The following is a description of a gene set: species: Homo sapiens from publication Chen Y, Wang X (PMID 31504780) Human Gene Set: MIR556_3P Genes predicted to be targets of miRBase v22 microRNA hsa-miR-556-3p in miRDB v6.0 with MirTarget v4 prediction scores > 80 (high confidence targets)., and this is the list of marker genes: MGME1, KCNMB3, KCNN4, ZNF704, TAF1, SAFB, PRTFDC1, G3BP2, SOCS1, ZNF695, PPM1B, CWC25, RIBC1, SMC5, COL4A1, HECW1, RAB22A, FCGR3A, DAPL1, CDH20, CLDND1, RFC3, CPEB3, CNOT2, DAB2IP, S1PR5, FYB1, KIN, HHIPL2, AGFG1, VTI1B, KCNH1, SLC49A4 (solute carrier family 49 member 4), CCN4, PSG2, PTPRF, VDR (vitamin D receptor), IHH, APLF, MED18, PRSS21 (NCBI Gene Id 9065), ERG, UPF1, CIP2A, TEK, KRT12, SENP6, KCTD4, ANGEL2, EHMT2, FCGR3B, PCP4, AP1AR, FGFR2, TOMM20L, MAB21L1, IMPA2, ELAVL4, ZNF33A, PPP2R5C, SENP2, PSG5, ZZZ3, DTX3L, PSG9, LAMA3, TTC1, DCTN4, CNNM4, SLC6A13, MTMR9, ATP6V1C2, ZNF548, TRAPPC8 (trafficking protein particle complex subunit 8), AK4, HOXD1, PI4K2B, MAFB, ELAVL1, GPR180, SLMAP, TYK2, PSG11, GRHL3, PSG3, RCBTB2 (RCC1 and BTB domain containing protein 2), PEX14, CCDC85A, MAPK9, BIRC3, GLIPR1, TCFL5, IKBIP, TRNT1, STX16, CYP3A7, FGF14, CNTN1, YBX1, NR3C2, PKIA, SLC27A3, SOX7 (SRY-box transcription factor 7), TM9SF3, FGFBP1, CHN2, SLC26A9, RGS9BP, CEACAM5, ZIC3, KATNAL1, TRIM36, DNAL1, UNC5C, BRD7, ENPP1, PTPRA, KIAA1958, HINFP, SPMIP1, PSMB9, ZFP14, PRR3, ARIH1, NUAK1, CYBRD1, DCAF7, RETNLB, TNPO1, AP4E1, PSG6, GPRIN1, DGKH, NPAS2, ZNF507, PRPF39, SLC25A4